Given this list of marker genes RUNX1, IL3, CBFB, ELF1, LIFR, here is a description of the gene set: part of: Transcriptional regulation by RUNX1 Reactome Pathway: RUNX1 regulates transcription of genes involved in interleukin signaling species: Homo sapiens The RUNX1:CBFB complex regulates transcription of at least a couple of genes involved in interleukin signaling. The LIFR gene, a direct transcriptional target of the RUNX1:CBFB complex, encodes the receptor for the leukemia inhibitory factor (LIF), a member of the interleukin-6 family. LIFR is implicated in hematopoiesis, embryo implantation, placental formation and nervous system development. In association with its co-activator ELF1, the RUNX1:CBFB complex stimulates transcription of the IL3 gene, encoding interleukin-3.